Given this list of marker genes Tenm2, Ctbp1, Gngt1, Pik3cg, Coq6, Ppl, Gnb4, Cdh17, Jak2, Rab13, Gng2, Snap91, Gng7, Snap29, Pik3ca, Atp6v1g1, Cyth2, Ppp1r9b (NCBI Gene Id 217124), Gnai2, Gphn, Coq4, Pik3r1, Ctnna2, Gnal, Trio, Gng8, Art2b, Atp6v1f, Jak1, Cdh3, Ryr1, Mcf2l, Atp6v1d, Fgf22, Dnajc6, Gng4, Picalm, Cdh15, Dgkb, Akap9, Nrbf2, Fbxo2, Gnaq, Gripap1, Coq8a (coenzyme Q8A, NCBI Gene Id 98364), Gnb2, Arsa, Gnb1, Coq3, Cnksr2, Pik3r2 (phosphoinositide-3-kinase regulatory subunit 2), Stxbp1, Gna14, Arap1, Pik3r4, C1qa, Nbea, Cdh5, Jup, Atp2a2, Atp6v1b1, Pik3r5, Ctnna1, Tepsin, Cdh20, Plekha4, Becn1, Cdh2, Gnat1, Apc, Gna15, Zfyve1, Atp6v1c1, Tprg1l, Vwc2, Pde4a, Btbd8, Olfm2, Ryr2, Snx10, Becn2, Traf6, Gnao1 (NCBI Gene Id 14681), Nmnat2, Rnf10, Cdh23, Dtna, Ap2b1, Amph, Gnaz, Pik3cd, Rph3a, Tiam1, Ctnnd1, Crkl, Gna11, Cdhr18, Coq7, Cdh24, Cdh9, Tamm41, Sgta, Stxbp5, Cltc, Nptx2, Gnat2, Gng10, Cdh22, Pik3r3, Cdh10, Doc2b, Gng5c, Farp1, Gnas, Coq2, Atp6v1g2, Atp6v1e1, Cnr2, Coq5, Bin1, Atm, Gng12, Nucb1, Dusp18, Emc2, Syn2, Pik3cb, Bsn, Apoe, Gnai3, Gng3, Tgm3, Pik3c3, Atr, Ank2, Sarm1 (sterile alpha and HEAT/Armadillo motif containing 1), Atp6v1a, Myd88, Syn3 (synapsin III), Olr1, Ctnnb1, Scrib, Cdh13, Gng11, Arhgef25, Gng13, Gng14, Gnai1, Cdh1, C1qb, C1qc, Gna13, Cdh11, Gngt2, Vinac1, Gng5, Tirap, Atp6v1h, Snx1, Dchs1, Cdh26, Gna12, Syn1, Dusp21, Olfm1, Scube2, Apc2 (NCBI Gene Id 97679), Cdh18, Atg14, Doc2a, Jak3, Rims1, Cdh7, Uvrag, Gfra1, Phb1, Ap2m1, Gnb5, Gnat3, Nod2, Atp6v1b2, Gnb3, Snap25, Cabp1, Kalrn, Pik3r6, Cyth1, Cdh6, Dgki, Magi2, Cadps, Cdh12, Ap2s1, Cdh8, Cdh4, Cdh19, here is a description of the gene set: Mouse Gene Set: GOCC_EXTRINSIC_COMPONENT_OF_MEMBRANE The component of a membrane consisting of gene products and protein complexes that are loosely bound to one of its surfaces, but not integrated into the hydrophobic region. studied in species Mus musculus